The following is a description of a gene set: Human Gene Set: GOBP_RETINAL_ROD_CELL_DIFFERENTIATION The process in which a relatively unspecialized cell acquires the specialized features of a retinal rod cell. studied in species Homo sapiens, and this is the list of marker genes: GNAT1, BBS4, SAMD11, NRL, SOX8, SOX9, NAGLU, RPGRIP1, CNTF, STAT3, GNAT2 (G protein subunit alpha transducin 2), SAMD7, NDP, RORB, RP1, RPGRIP1L, BBS10, NTRK2